Given this list of marker genes PCBP1, BBS9, AHCTF1, ARHGAP32, SHANK2, MDGA2, ZSCAN32, ARFGEF1, DIPK2A, CDYL2, ABCC2, GCNT3, RBM14, RBM12, S100A7A, IKZF2, PHC1, EMSY, CFAP68, IRX6 (iroquois homeobox 6), ANKRD44, GATC, PPP4R2, MAML2 (mastermind like transcriptional coactivator 2), TNKS2, PLPBP, CRYBG3, SMARCD1, UBE2QL1, FBXO45, LINC02693, TMOD3, NR3C2, CLECL1P, CACNA1H, TXNRD2, PPME1, GAL3ST3, VPS35L, NUS1, ZDBF2, RFX7, MED20, MSI1, GEN1, RNF144B, KDM7A, POLR1B, RAB14, here is a description of the gene set: from publication Chen Y, Wang X (PMID 31504780) Human Gene Set: MIR490_3P Genes predicted to be targets of miRBase v22 microRNA hsa-miR-490-3p in miRDB v6.0 with MirTarget v4 prediction scores > 80 (high confidence targets). species: Homo sapiens